Given this list of marker genes MAFF, SNORA28, MIR22HG, HLA-DRB6, MORC2-AS1, NR1D2, PIK3R5, CHRAC1, TMEM131L, KTI12, USF3, ZBTB10 (zinc finger and BTB domain containing 10), TCF7L2, CCDC66, TSPAN32, ABHD13, DUSP1, LINS1, JUN, SNHG15 (NCBI Gene Id 285958), NAAA, SHISAL2A, PAIP1, S100A8, RNF139, STRIP1, CASP1, FYTTD1, TSC22D1, DTX3L, BMPR2, ANXA1, JMY, CD69, ANKRD36C, WDR19, STXBP5, CDC14A, INO80, JUNB, PLEK, FAM200B, SAMHD1, TMEM9B, TBXAS1, SLC7A6, IL7R, JADE1, AEN, GABBR1, EPB41L4A, UBE2G2, TRIM73, TOE1, SESN3, RTL9, FCMR, UNK, FHIT, MTOR, CLEC7A, CNST, SLC12A7 (NCBI Gene Id 26129), PON2, PRRX1, UBASH3B, NAP1L5, RAPGEF1, SLC25A33, NR4A2, ELOA, PCSK5, FOSL2, TENM1, TPRG1L, TRAPPC13, WHAMM, ZFAND2A, CD83, CSGALNACT1, SLC26A11, VAV3, USPL1, ATG14, ARHGAP21, ZDHHC11, SGK1, GNPTG, MPP7, MARCHF8, OCRL, CDK5R1, ZNF592, AHNAK, FBXO33, CDK12, ATP8A1, ZBED10P, COQ10A, TPM2, TRANK1, ZNF10, PSTK, EPHA4, BACH2, PTP4A1 (protein tyrosine phosphatase 4A1), ZNF552, GBP4, EXOG, HEG1, TRAF6, SETX, MARCHF2, SYNM, NCOA1, SNN, PLEKHA1, IPCEF1, MAN2B2, TRIB1, SAMD4B, NRIP1, NFKBIZ (NFKB inhibitor zeta), RIOK1, COQ10B, LCOR, RAP1GAP2, ENSG00000280119, PCNX2, POLR3B, ZXDB, KAT6B, ZNF805, BTRC, CIRBP, PIM1, RAPGEF2, LMTK2, SCGB3A1, RGS2, ZNF8, NEK8, MOCS2, TOB1, NOM1, YRDC, ERP27, MFSD1, TRAPPC10, VPS9D1, G0S2 (G0/G1 switch 2), IQCE, NSD1, POLR3E, EID3, KRT73, TNIP2, PELI2, LRPAP1, MAP4K4, APOBEC3A, MTUS1, HERC6, C9orf78, FIS1, MIR646HG, PARP8, EMB, ITGA6, TTN, CUX1, ZDHHC3, IRS2, POLR2M, SKIL, TYROBP, CTSO, ENC1, GSAP, CASP4, KLF4, AK5, SOCS3, LMF2, DNAH5, IL11RA (interleukin 11 receptor subunit alpha), ITPRIP, ASAH1, GPRASP1, DPEP2, TNFSF8, LATS1, SOAT1, ZNF394, KLF2, here is a description of the gene set: Genes up-regulated in comparison of untreated CD4 T cells at 0 h versus the cells treated with IL4 and anti-IL12 at 72 h. species: Homo sapiens The aim of this dataset was to study in detail the transcription kinetics initiated by cytokine IL-4 in early differentiation of Th2 cells. from publication Elo LL, Järvenpää H, Tuomela S, Raghav S, Ahlfors H, Laurila K, Gupta B, Lund RJ, Tahvanainen J, Hawkins RD, Oresic M, Lähdesmäki H, Rasool O, Rao KV, Aittokallio T, Lahesmaa R (PMID 20620947) Human Gene Set: GSE17974_CTRL_VS_ACT_IL4_AND_ANTI_IL12_72H_CD4_TCELL_UP